The following is a description of a gene set: species: Mus musculus Mouse Gene Set: GOBP_POSITIVE_REGULATION_OF_TRANSLATIONAL_INITIATION Any process that activates or increases the frequency, rate or extent of translational initiation., and this is the list of marker genes: Tnf, Ythdf1, Larp1, Boll, Dhx29, Uhmk1, Dnajc3, Polr2g, Ythdf3, Sh3bgrl, Habp4, Khdrbs1, Ythdf2, Akt2, Ddx3x, Dazl, Mettl3, Mtor, Eif2b5, Eif2ak4, Rps6kb1, Rxra, D1Pas1, Pkp1, Rps6kb2, Nck1 (NCBI Gene Id 319390)